Given this list of marker genes MED12, ABCB4, SLC25A13, FADD, FOCAD, here is a description of the gene set: studied in species Homo sapiens Human Gene Set: HP_PORTAL_INFLAMMATION Infiltration of portal fields by inflammatory cells. Portal inflammation